The following is a description of a gene set: Human Gene Set: GOBP_RECEPTOR_LOCALIZATION_TO_NON_MOTILE_CILIUM species: Homo sapiens A process in which a receptor is transported to, or maintained in, a location within a non-motile cilium., and this is the list of marker genes: ARL13B, IFT80, TUB, ARL13A, BBIP1